The following is a description of a gene set: Mouse Gene Set: GOBP_POSITIVE_REGULATION_OF_INTEGRIN_MEDIATED_SIGNALING_PATHWAY species: Mus musculus Any process that activates or increases the frequency, rate or extent of integrin-mediated signaling pathway., and this is the list of marker genes: Lama1, Lims2, Nid1, Lama2, Dab2, Lamc1, Lamb1, Lims1, Emp2, Flna (NCBI Gene Id 245705), Loxl3, Pcsk5, Lamb2, Cd63